The following is a description of a gene set: Human Gene Set: MIR1236_5P from publication Chen Y, Wang X (PMID 31504780) Genes predicted to be targets of miRBase v22 microRNA hsa-miR-1236-5p in miRDB v6.0 with MirTarget v4 prediction scores > 80 (high confidence targets). species: Homo sapiens, and this is the list of marker genes: DOCK8, KY, GABBR2, STON2, MYH1, WDR47, VPS41, MPZL3, ARSL, MFF, DAZ2, SELENON, SOHLH2, ZZZ3, TNF, SLC44A5, SERPIND1, CCDC169-SOHLH2, TMCO6, ARHGAP23, PUS7L, FCRL1, WWC3, CPSF4, NUSAP1, POLR2H, LRRC8C, FNDC3B, COL14A1, HRG, CREB1, DAZ3, CHD6, RIPPLY3, BNC2, KIAA1549, FOXP1, CCNT1, USP51, PRKAR1A, ASB13, OSBP, TMEM223, DISC1, ATP6V1E1, LHPP, PXT1, SLC10A1, AIF1L, AMDHD1 (amidohydrolase domain containing 1), ZNF614, ZNF697, ICMT, ALDH3A2, GAB1, DAZ4, OGG1, CLMN, DAZ1, GDNF, EIF4A1, SLC25A12, ADAM9, C2orf72, HAX1, AJUBA, UBAC1, LMO4, TEAD1, NR1D2, FAM180A, HOMER1, PIGR (polymeric immunoglobulin receptor), CCDC57, MORC1, SLC4A4, CA10, FOLH1B, RAD9B, PLEKHA2, PTPN4